Given this list of marker genes Loxl2 (NCBI Gene Id 94352), Capn7, Utrn (NCBI Gene Id 22288), Col2a1, Capn1, Mmp7, Capn6, Pcolce, Col13a1, Bmp7, Actc1, Itgal, Adam19, Bmp1, Loxl4, A2m, Nid2, Phykpl, Icam2 (intercellular adhesion molecule 2), Ctss, Col4a5, Spock3, Mfap4, Sgcd, Itga2b, Ibsp, Klkb1, Emilin2, Sgca, P3h2, Mmp13, Vtn, Actg2, Col6a6, Mmp12, Tnn, Dcn, Sdc1, Capn15, Col1a2, Cma1, Tll2, Capn9, Itga2 (NCBI Gene Id 16398), Col11a2, Acta1, Scube3, Mmp25, Try10, Bmp10, Ltbp2, P4hb, Fbln5, Mfap2, Col12a1, Col8a2, Prss2, Mmp15, Htra1, Col9a1, Pcolce2, Mmp3, Mmp17, Klk7, Sntb2, Ltbp3 (NCBI Gene Id 16998), Ceacam1, Loxl1 (NCBI Gene Id 16949), Icam5, Mmp8, Mfap5, P3h3, Prss3, Col6a5, Cdh1, Plod2, Mmp2, Sdc3, Spp1, Plod3, Optc, Capn5, Ppib, Mmp19, Col20a1, Plg, Capns2, Dag1, Lama4, Ctsg, Col18a1, Bsg, Tmprss6, Loxl3, Ctsd, Acan, Col15a1, Timp1, Col17a1, Tnxb, Mmp20 (NCBI Gene Id 30800), Col4a6, Scube1, Hapln1, Itga5, Itgb7, Col10a1, Drp2, Dtnb, Mmp14, Prkca, Fgf2, Elane, Adam15, Itgb2, Col8a1 (NCBI Gene Id 12837), Icam4, Col7a1, Itga3, Col6a1, Tgfb1, Tnc, Col25a1, Cast, Itga4, Col24a1, Capn8, Capn13, Col19a1, Itgb5, Sgce, Lum, Itgax, Bgn, Sgcb, Mmp11, Sspn, Bmp4, Comp, Lox, Col4a2, Tnr, Mmp10, Fgg, Col5a3, Adamts4, Sntb1, Adam12, Itgb8, Adam8, here is a description of the gene set: Reactome Pathway: Extracellular matrix organization electronically inferred by orthology from the curated human pathway This event has been computationally inferred from an event that has been demonstrated in another species.<p>The inference is based on the homology mapping from PANTHER. Briefly, reactions for which all involved PhysicalEntities (in input, output and catalyst) have a mapped orthologue/paralogue (for complexes at least 75% of components must have a mapping) are inferred to the other species. studied in species Mus musculus